The following is a description of a gene set: Migraine is a chronic neurological disorder characterized by episodic attacks of headache and associated symptoms. Human Gene Set: HP_MIGRAINE species: Homo sapiens Migraine, and this is the list of marker genes: ALPK1, MT-TF, GP9, IFNGR1, GRIN2A, GP1BB, DEPDC5, ZNF365, COL4A1, NFIX, MEFV, P2RY11, ANO1, MT-TK, MLH1, MT-TL1, EPCAM, ESR1, MT-CYB, SMAD2, FGFR2, MYORG, KRAS, RRM2B, MT-TV, FAS, FGFR3, TLR4, DNM1L, STARD7, SMAD4, EPHB4, CTSH, POLG, NOTCH3, ENG, NDP, SH2B1, SLC1A3, NOP56, GATA2, ADA2, ADAMTSL1, MSH2, HTR1A, POLD1, PDGFRB, HLA-DQB1, AMACR (NCBI Gene Id 23600, alpha-methylacyl-CoA racemase), NLRP3, GDF2, STIM1, PRRT2, MPL, MT-CO1, COL3A1, TNF, MRPL39, UBAC2, SH2B3, MT-TH, TNFRSF1A, MYD88, MT-ND4, NF1, MVK, SPOP, PRORP, TGFBR2, HLA-B, FRMD5, IL12A-AS1, PIK3CA, RELN, SMARCB1, HLA-DRB1, MT-CO3, MT-TC, MSH6, PDGFB, MT-TS2, HCRT, POLG2, ADAMTS3 (NCBI Gene Id 9508), MT-TQ, C4A, SRPX2, GP1BA, MOG, SLC2A1, CACNA1A, BRCA2, ATM, RPS20, STAT4 (signal transducer and activator of transcription 4), ERAP1, PMS1, ATP1A2, CHEK2, SEMA4A, IL10, SCN1A, GABRG2, SLC25A4, COPB1, KLRC4, PMS2, RASA1, EDNRA, ZFTA, CSNK1D, APP, TP53, RNASEH1, CCR1, JAG1, IL12A, GPR101, SMAD3, JAK2, OPA1, ACVRL1, SLC6A19, SMARCAL1, LGI1, KCNA1, PLAAT3, IL23R, TWIST1, MT-CO2, MUTYH, POLE, CALR, KCNK18, PGK1, AIP, MLX, TREX1, BMPR1A, TET2, MT-ND5, MT-ND6, NAA60 (N-alpha-acetyltransferase 60, NatF catalytic subunit), TWNK (twinkle mtDNA helicase), TNFSF4, MT-ND1, MT-TW, CLTRN, IL12B, COL5A1, PEX11B, SQOR, SUFU, ACSF3